Given this list of marker genes RAB26, ITGA2, MMD, NEAT1, KLF10, KMT2E, CDKN1C, ARHGEF3, FOS, KLF9, MT2A, MAML3, ETS2, AKAP10, PPARA (NCBI Gene Id 84730), MACROH2A1, MSX2, SNX5, TALAM1, KIF13B, H19, MALAT1, PKM, PDE4C, CDH17, NFKBIZ, MT1E, NF1, ELF3, CAMK2D, TBC1D4, ERO1B, BCL3, MT1F, MT1X, here is a description of the gene set: studied in species Homo sapiens from publication Rodrigues S, De Wever O, Bruyneel E, Rooney RJ, Gespach C (PMID 17334389) Human Gene Set: RODRIGUES_NTN1_AND_DCC_TARGETS Genes down-regulated in HCT8/S11 cells (colon cancer) which lack DCC and stably express NTN1. Deleted in colon cancer (DCC) and UNC5 function as netrin dependence receptors by inducing apoptosis in the absence of their ligand and accordingly were recently designated as putative conditional tumor suppressors. Herein, we determined whether netrin-1 and its receptors are implicated in cancer cell invasion and tumor progression. Expression of DCC, UNC5 and adenosine A2B-receptors (A2B-Rs) was investigated by reverse transcription polymerase chain reaction in human colon cancer cells. The impact of DCC restitution and netrin-1 was evaluated on collagen type I invasion, tumor growth and metastasis in nude mice, cancer cell survival and gene expression profiling. Flow cytometry, poly(ADP-ribose)polymerase-1 and caspase-8 activation were used to evaluate the impact of DCC on cell death. Both netrin-1 and A2B-R activation induced the invasive phenotype through the Rho-Rho kinase axis in DCC-deficient human colorectal cancer cells. Restitution of wild-type DCC blocked invasion induced by netrin-1, A2B-R agonist and other agents. Ectopic expression of netrin-1 led to increased growth of human colon tumor xenografts in athymic mice. Conversely, introduction of wt-DCC in kidney MDCKts.src-ggl cells strongly inhibited metastasis in lymph nodes and lungs and increased sensitivity to apoptosis in hypoxia. DNA microarrays revealed that netrin and DCC had common and divergent impacts on gene expression linked to cell cycle, survival, surface signaling and adhesion. Our findings underscore that netrin is a potent invasion and tumor growth-promoting agent and that DCC is a metastasis suppressor gene targeting both proinvasive and survival pathways in a cumulative manner.